The following is a description of a gene set: Human Gene Set: HP_ABNORMAL_CIRCULATING_ANTIMULLERIAN_HORMONE_CONCENTRATION Abnormal circulating antimullerian hormone concentration species: Homo sapiens Any deviation from the normal range of the antimullerian hormone, a peptide produced by the granulosa cells of follicles. Anti-Mullerian hormone (AMH), also known as Mullerian inhibiting substance, is produced by the granulosa cells of small antral follicles of the ovary. AMH has an inhibiting role in the ovary, contributing to follicular arrest. AMH levels in women are low until the age of 8, rise rapidly until puberty and decline steadily from the age of 25 until menopause, when AMH production ceases., and this is the list of marker genes: SPIDR, XRCC2, HROB, AR, ESR2, DHX37, KASH5, SYCP2L, C14orf39, AMH, SPATA22, FANCM, AMHR2, MEIOB